The following is a description of a gene set: species: Mus musculus Mouse Gene Set: GOBP_VISCERAL_SEROUS_PERICARDIUM_DEVELOPMENT The progression of the visceral serous pericardium from its formation to the mature structure. The visceral serous pericardium is the inner layer of the pericardium., and this is the list of marker genes: Vcam1, Itga4, Hand2 (NCBI Gene Id 15111), Tgfbr3, Epor (erythropoietin receptor), Wt1, Rxra, Epo, Pdpn